The following is a description of a gene set: studied in species Homo sapiens Human Gene Set: GOBP_MODIFICATION_OF_POSTSYNAPTIC_STRUCTURE Any process that modifies the structure of a postsynapse., and this is the list of marker genes: PFN2, ARHGAP44, CTNNA2, CFL1, RHOB, RAP1B, PDXP (pyridoxal phosphatase), STAU1, CAP1, PRMT8, ABI3, EGLN1, WASF1, SPTB, CTTNBP2, PFN1, RHOA, AMOT, STRN4, BAIAP2, ITPKA, CTTN (NCBI Gene Id 2017), ITSN1, CHMP2B, FILIP1, SARM1, DLGAP3, DRD1, MRTFB, DIXDC1, DLGAP4, AGAP1, CAMKV, WASF3, CYFIP1